The following is a description of a gene set: from publication Fontaine JF, Mirebeau-Prunier D, Franc B, Triau S, Rodien P, Houlgatte R, Malthièry Y, Savagner F (PMID 17968324) Conventional histology failed to classify part of non-medullary thyroid lesions as either benign or malignant. The group of tumours of uncertain malignancy (T-UM) concerns either atypical follicular adenomas or the recently called 'tumours of uncertain malignant potential'. To refine this classification we analysed microarray data from 93 follicular thyroid tumours: 10 T-UM, 3 follicular carcinomas, 13 papillary thyroid carcinomas and 67 follicular adenomas, compared to 73 control thyroid tissue samples. The diagnosis potential of 16 selected genes was validated by real-time quantitative RT-PCR on 6 additional T-UM. The gene expression profiles in several groups were examined with reference to the mutational status of the RET/PTC, BRAF and RAS genes. A pathological score (histological and immunohistochemical) was estimate for each of the T-UM involved in the study. The correlation between the T-UM gene profiles and the pathological score allowed a separation of the samples in two groups of benign or malignant tumours. Our analysis confirms the heterogeneity of T-UM and highlighted the molecular similarities between some cases and true carcinomas. We demonstrated the ability of few marker genes to serve as diagnosis tools and the need of a T-UM pathological scoring. Human Gene Set: FONTAINE_FOLLICULAR_THYROID_ADENOMA_DN Genes down-regulated in follicular thyroid adenoma (FTA) compared to other thyroid tumors. studied in species Homo sapiens, and this is the list of marker genes: SPI1, ELK4, KPNA2, DPP4 (dipeptidyl peptidase 4), BAP1, CD38, MYC, FAM117A, RPS6KA5, PTGES, CLGN, SYP, VDAC1, KLF4, BNIP3 (NCBI Gene Id 664), FAM107A (family with sequence similarity 107 member A), IGSF10, ZNF275, MAN1A1, MDH1, SCEL, ZMYM6, PICK1, SENP6, ZNF217, CLDN7, LPAR1, IFI30, GPI, TTC7B, RBBP4, PITPNA, HCLS1, GFPT2 (glutamine-fructose-6-phosphate transaminase 2), LILRB3, PCSK6, CD274, FABP5, CITED1, S100A6, CD47, S100A12, PLCG2, NOTCH1, GLRX2, S100A10, ECM1, CCL11, EPRS1, CTIF, CASP4, CCND3, BANF1, COX7B, DCLK1, TMEM14B, MAP2, C1QBP, ATR, SPDEF, KLRK1, MLLT1, ABCA8, KLRD1, RGS19 (NCBI Gene Id 10287), WAS, SLF2, CLDN1, TENM1, IL2RA (NCBI Gene Id 3559)